The following is a description of a gene set: The lipid bilayer surrounding a postsynaptic recycling endosome. studied in species Mus musculus Mouse Gene Set: GOCC_POSTSYNAPTIC_RECYCLING_ENDOSOME_MEMBRANE, and this is the list of marker genes: Tfrc, Myo5b, Abhd17a, Abhd17b, Akap5, Zdhhc2, Rab11fip3